The following is a description of a gene set: Genes down-regulated in comparison of control polymorphonuclear leukocytes (PMN) at 3 h versus PMN treated with F. tularensis vaccine at 3 h. We demonstrated recently that both constitutive and FAS-triggered apoptosis of human neutrophils are profoundly impaired by Francisella tularensis, but how this is achieved is largely unknown. To test the hypothesis that changes in neutrophil gene expression contribute to this phenotype, we used human oligonucleotide microarrays to identify differentially regulated genes in cells infected with F. tularensis strain LVS compared with uninfected controls. In order to examine the effect of F. tularensis on the neutrophil transcriptome, we performed microarray expression analysis on human neutrophils treated with F. tularensis subsp. holarctica live vaccine strain (LVS). Human Gene Set: GSE37416_CTRL_VS_3H_F_TULARENSIS_LVS_NEUTROPHIL_DN from publication Schwartz JT, Bandyopadhyay S, Kobayashi SD, McCracken J, Whitney AR, Deleo FR, Allen LA (PMID 22986450) studied in species Homo sapiens, and this is the list of marker genes: PIGA, KCTD11, SCN8A, IPPK, ESPL1, OXSM, TPI1, RHBG, ADRB1, ONECUT2, OR51B5, PGAM1, BAAT, TMEM170A (NCBI Gene Id 124491), ABTB2, ETS2, PER1 (NCBI Gene Id 5187), RTL8C, ANKRD37, BHLHE40, CHMP2A, DDX50, TCAF2, HILPDA, MRGBP, DDX41, LGALS8, FFAR3, ADORA1, PTS, ZBTB21, PLIN2, ALLC (NCBI Gene Id 55821), RBFOX2, CCDC47, FUT11, APOF, MYNN, NFE2L2, BNIP3, ENSG00000291149, MCMDC2, DDIT4, ARHGEF12, CSRNP1, HK2, PDK1, RNMT, KIFC2, IL1A, EGR3 (early growth response 3), SCYL2, SIX1, PDGFRL, TNF, LIN9, ETV3, VDAC1, ENO1, MFAP1, FAM210A, PSMA6, GRPEL1, GSG1L, THUMPD3, ZNF295-AS1, UBE2V2, ZNF12, PAF1, EBLN2, KLK5, JRKL, TRAM1L1, TAF9B, PDGFB, SLC7A5, NOVA2, MNX1, ABCB9, ICAM1, INSM1, EFCAB3, HCAR3, FEM1C, FCAR, MGAT5B, FAM3D, ZFC3H1, P4HA1, IRGQ, VGLL4, SLC24A5, TGM1 (transglutaminase 1), MTFP1, NXT1, ZNF654, ADPRS, ASCC1, ABT1, LRRC20, PLA2G12B, LPIN3, SCARA3, ZNF556, SEC24A, SERTAD3, CLK1 (NCBI Gene Id 1195), ECD, ZC2HC1B, PPP1R3E, LONP1, UBAP1, RSPO1, DCAF1, IVNS1ABP (NCBI Gene Id 51489), ACTR3, ALDOA, RALGAPA1, KIF3A, NR1I2, NUP58, ZBTB1, NGLY1, FAM177A1, SBNO2, ANKZF1, G0S2, TCAP, PTGS2, MIF, IL18BP, LDHA, ISG20L2, DNA2, DCTN6, SYT3, PPP2R2D, ALKBH5, KRTAP4-8, NHLRC3, RAB33A, PKM, PLK3, RAB1A, ARL5B, BRPF3, FAM162A, SPMIP1, CNGA1, ENAM, MAGT1, IRF2BP2, KIRREL1, MSMB, MAPK7, NR2F1-AS1, PGK1, FGF11, SPTSSB, SLC35B2, C1S, KDM3A, DNAJC22, LINC00471, ALDOC, CYB5D1 (cytochrome b5 domain containing 1), BCL10, TAF13, F10, SCUBE2, OXSR1, BZW1, ZPR1, COA1, PPP1R15A, SUPT6H, SPTY2D1, HMX1, CDK5, TRAF1, WFDC8, GTPBP1, MTARC2, NLRP3, GAD1, GYPE, TRA2A, NABP1, VLDLR, SAR1B, PNPLA1, ZNF292, RAB8B, RLF, CCDC138